The following is a description of a gene set: studied in species Homo sapiens Human Gene Set: GOBP_NEURON_PROJECTION_GUIDANCE The process in which the migration of a neuron projection is directed to a specific target site in response to a combination of attractive and repulsive cues., and this is the list of marker genes: EFNA2, SCN1B, APP, MYH10, EPHA5, PLEKHG4, EFNA4, IGSF9, B4GAT1, DSCAM, EFNA5, ERBB2, TUBB2B, BSG, CRPPA (CDP-L-ribitol pyrophosphorylase A), BOC, BMPR2, RYK, SEMA3D, LMO4, NTN3, LMX1A, ARTN, NOG, DCC, KIF5A, SEMA4A, KIF21A, EPHA3, DVL1, PLEKHG4B, SLIT2, LHX1, CYFIP2, NKX2-1, SEMA3E, SEMA3G, CNTN4, UNC5C, NEXN, EXT1, ENAH, FEZ1, SEMA3F, SEMA3A, UNC5D, GDF7, CHN1 (NCBI Gene Id 27011), SHH, GLI3 (GLI family zinc finger 3), SEMA5B, LHX2, CYFIP1, CXCL12, UNC5A, EPHB1, PTK2, NPTN, EFNB2, EPHA6, YTHDF1, KIF5B, CSF1R, MATN2, EFNB3, GBX1, SEMA5A, OR10A4 (NCBI Gene Id 81350), EDN3, EPHB2, NOTCH1, SEMA4G, RPL24, LAMB2, ARHGEF40, GATA3, LAMA2, NCAM1 (NCBI Gene Id 4684), KIFC2, LHX3, KLF7, ARX, TUBB3, ADAM17, CHL1, ECE1, PTPRM, USP33, B3GNT2 (NCBI Gene Id 55878), FGF8, ULK2, ROBO2, ALCAM, LHX9, SEMA6C, L1CAM, EMB, PLXNA1, DRGX, EDN1, NRXN1, SLIT1, FYN, PRKCQ, SIAH1, CDK5R1, NOTCH2, LGR6, BMP7, ARK2C, SEMA4C, POU4F3, EPHA8, FOXG1, TBR1, PTK7, FEZ2, ANOS1, EFNA3 (ephrin A3), GFRA3, NDP, GBX2, PLXNA4, NRXN3, ATOH1, RAC3, ISL2, RET, OPHN1, NOVA2, SEMA6B, ATOH7, EFNA1, VEGFA, SEMA4F, NTN4, RPS6KA5, NECTIN1, WNT7B, ETV1, ARHGAP35, HOXA2, NFIB, HDAC6, BMPR1B, EPHA10, SEMA3B, NFASC, CNTN6, MYOT, EVL, TRIO, WNT3A, TNR, SLIT3, DAG1, DPYSL5, RELN, ARHGEF25, EPHB3, WNT3, VANGL2, MYCBP2, GAP43, SEMA6D, NEO1, PAX6, KALRN, MYPN, LHX4, NTN1 (netrin 1), ISL1, FLRT3, CDH4, HMCN2, SMAD4 (NCBI Gene Id 4089), SEMA7A, PGRMC1, EFNB1, NRCAM, RAC1, ROBO1, PTPRH, LYPLA2, BDNF, NTRK1, NR4A3, DLX5, UNC5B, LGI1, PCDHAC2, NELL2, CELSR3, PLXNA3, EVX1, TTC8 (NCBI Gene Id 123016), PTCH1, CNTN5, PTPRJ, KIAA1755, VAX1, CNTN2, EPHB6, EPHA7 (EPH receptor A7), CDK5R2, APBB2, PTPRO, CNTN1, DSCAML1, KIF5C, ROBO4, VASP, SOS1, OTX2, POU4F2, NGFR, SEMA4B, EPHA4, FEZF2, FOXD1, SMO, SEMA6A, ABLIM1, BCL11B, ROBO3, NOTCH3, NRP2, PALLD, TGFB2, MEGF8, FZD3, NRP1, GDNF, FLRT2, GLI2, EGR2, PLA2G10, SEMA3C, SEMA4D, EDNRA, FEZF1, CDK5, WNT5A, DRAXIN